Given this list of marker genes CPT2, SLC2A1, SLC16A1, ACAT1, UCP2, BDH1, SLC25A20, OXCT1, here is a description of the gene set: Human Gene Set: WP_KETOGENESIS_AND_KETOLYSIS Ketogenesis and ketolysis species: Homo sapiens